The following is a description of a gene set: studied in species Homo sapiens Reactome Pathway: Regulated Necrosis Necrosis has traditionally been considered as a passive, unregulated cell death. However, accumulating evidence suggests that necrosis, like apoptosis, can be executed by genetically controlled and highly regulated cellular process that is morphologically characterized by a loss of cell membrane integrity, intracellular organelles and/or the entire cell swelling (oncosis) (Rello S et al. 2005; Galluzzi L et al. 2007; Berghe TV et al. 2014; Ros U et al. 2020). The morphological hallmarks of the nectotic death have been associated with different forms of programmed cell death including (but not limited to) parthanatos, necroptosis, glutamate-induced oxytosis, ferroptosis, inflammasome-mediated necrosis etc. Each of them can be triggered under certain pathophysiological conditions. For example UV, ROS or alkylating agents may induce poly(ADP-ribose) polymerase 1 (PARP1) hyperactivation (parthanatos), while tumor necrosis factor (TNF) or toll like receptor ligands (LPS and dsRNA) can trigger necrosome-mediated necroptosis. The initiation events, e.g., PARP1 hyperactivation, necrosome formation, activation of NADPH oxidases, in turn trigger one or several common intracellular signals such as NAD+ and ATP-depletion, enhanced Ca2+ influx, dysregulation of the redox status, increased production of reactive oxygen species (ROS) and the activity of phospholipases. These signals affect cellular organelles and membranes leading to osmotic swelling, massive energy depletion, lipid peroxidation and the loss of lysosomal membrane integrity. Different mechanisms of permeabilization have emerged depending on the cell death form. Pore formation by gasdermins (GSDMs) is a hallmark of pyroptosis, while mixed lineage kinase domain-like (MLKL) protein facilitates membrane permeabilization in necroptosis, and phospholipid peroxidation leads to membrane damage in ferroptosis. This diverse repertoire of mechanisms leading to membrane permeabilization contributes to define the specific inflammatory and immunological outcome of each type of regulated necrosis. part of: Programmed Cell Death, and this is the list of marker genes: RIPK3, CHMP2A, CHMP4A, SDCBP, CDC37, CASP8, CHMP3, TRAF2, IL18, CHMP4B, IL1A, UBB, TNFSF10, HMGB1, CASP3, UBE2L3, FAS, CHMP4C, FADD, PDCD6IP, ELANE, GSDME, OGT, TNFRSF10A, CYCS, MLKL, TRADD, HSP90AA1, PELI1, IRF2, RIPK1, TP63, XIAP, UBC, CASP5, ITCH, FLOT1, RIR1, CFLAR, RPS27A, STUB1, BAX, UBA52, CASP4, CHMP6, PRKN, NS, TP53, CHMP7, GZMB, TNFRSF10B, FASLG, IRF1, BIRC2, FLOT2, GSDMD, CASP1, CHMP2B, BAK1, IL1B, BIRC3